Given this list of marker genes PRSS22, TIMP2, SLC45A3, ADORA2B, B3GNT3, DOCK4, CRACD, FREM2, FAM83A, COL12A1, GOLM1, TIMP1, PWWP3B, ULBP2, NCAM2, ZBTB25, FHL2, GFRA1, GPR87, ASPH, PTPN13, TMEM45B, RETREG1, TACC1, CA2, FN1, PPARG, PLD1, SPOCK1, UGT2B15, MAOA, NECAB1, ANXA1, CROT, HLA-DRB1, IGSF8, OPN3, BRIP1, SHC1, CGNL1, LAMC2, CYP1B1, ELL2, SGK3, TUBA1A, CDCA7L, STEAP4, CYSRT1, ETV5, C1orf226, ISOC1, CPE, AQP3, MSMB, NTN4 (NCBI Gene Id 95736), IGFBP5, SLC1A2, MAFB, METTL21A, TTC9, CBLB, MT1X, BAIAP2L1, DHRS2, TUBA4A, TMC6, ABCC3, SYT13, PTGER3, S100A6 (NCBI Gene Id 6277), FCRLB, ARSJ, KRT86, EPHA7, CCNYL1, SLC16A3, MYEOV, ASS1, DLC1, SLC24A3, ALOXE3, ITPRIPL2 (ITPRIP like 2), HSPA13, UBALD2, AGR2, CEACAM1, EPAS1, MAP4K3-DT, ST3GAL5, CLVS1, IL18, MYBL1, ADI1, SOX3, ELOVL2 (ELOVL fatty acid elongase 2), MYB, RAPGEF5, ZNF365, MLLT11, FAM110C (NCBI Gene Id 642273), MT2A, PHLDA2, CADPS2, SESN2, LAD1, SAT1, EMP1, CALCR, here is a description of the gene set: Human Gene Set: PEDERSEN_METASTASIS_BY_ERBB2_ISOFORM_4 species: Homo sapiens HER2 is a tyrosine kinase receptor causally involved in cancer. A subgroup of breast cancer patients with particularly poor clinical outcomes expresses a heterogeneous collection of HER2 carboxy-terminal fragments (CTFs). However, since the CTFs lack the extracellular domain that drives dimerization and subsequent activation of full-length HER2, they are in principle expected to be inactive. Here we show that at low expression levels one of these fragments, 611-CTF, activated multiple signaling pathways because of its unanticipated ability to constitutively homodimerize. A transcriptomic analysis revealed that 611-CTF specifically controlled the expression of genes that we found to be correlated with poor prognosis in breast cancer. Among the 611-CTF-regulated genes were several that have previously been linked to metastasis, including those for MET, EPHA2, matrix metalloproteinase 1, interleukin 11, angiopoietin-like 4, and different integrins. It is thought that transgenic mice overexpressing HER2 in the mammary glands develop tumors only after acquisition of activating mutations in the transgene. In contrast, we show that expression of 611-CTF led to development of aggressive and invasive mammary tumors without the need for mutations. These results demonstrate that 611-CTF is a potent oncogene capable of promoting mammary tumor progression and metastasis. from publication Pedersen K, Angelini PD, Laos S, Bach-Faig A, Cunningham MP, Ferrer-Ramón C, Luque-García A, García-Castillo J, Parra-Palau JL, Scaltriti M, Ramón y Cajal S, Baselga J, Arribas J (PMID 19364815) Genes regulated in MCF7 cells (breast cancer) by expression of the full-length and truncated (611-CTF) forms of ERBB2 at 60 h time point.